The following is a description of a gene set: Human Gene Set: GOBP_EOSINOPHIL_MIGRATION The movement of an eosinophil within or between different tissues and organs of the body. species: Homo sapiens, and this is the list of marker genes: CX3CL1, CCL16, CCL7, CCL26, CCL1, CCL24, CCL4, SCG2, CCL22, CD300A, CCL5, LGALS3, DAPK2, CCL19 (C-C motif chemokine ligand 19), CCL11, CCL8, CCL4L2, ADAM8, CCL21, CCL13, CCL3, CCL25, CCL2, PTGER4, EPX